Given this list of marker genes Slamf8 (SLAM family member 8), Ccl21d, Spi1, Calr, Ccl21f, Il12a, Ccr7, Slamf1, Gas6, Ccr6, Ccl21e, Ccl21a, Tnfsf18, Ccl21b, C1qbp (NCBI Gene Id 28127), here is a description of the gene set: species: Mus musculus Any process that modulates the frequency, rate or extent of dendritic cell chemotaxis. Mouse Gene Set: GOBP_REGULATION_OF_DENDRITIC_CELL_CHEMOTAXIS